Given this list of marker genes ATXN1 (ataxin 1), ADAM28, M6PR, FAM234B, ZDHHC23, SLC25A35, SSTR3, FOXD2, ACHE, ADPRHL1, C19orf38, DLD, WARS1, CACNA1B, NHERF4, SCN4A, ABHD3, ZSWIM5, HCN3, MORC2, ANKRD42, MCTP2, ZSWIM6, SCARB1, NCAN, SUV39H1, LRRC8B, HOMEZ, MAN1B1, ARID3B, MAP3K10, TYSND1, CEP85, MAP6, TDG, RMND5A, IL6R, PRRC1, C1orf210, IER2, PLXNA1, PCTP, ATXN3, INTS7, TRIM71, GALNT14, RBM20, MRPL30, SPATA31D4, DHX33, NDUFA2, ANKRD50, MAP3K13, SCUBE3, PI4K2B, RASSF3, ITGA8, SLC6A17, MAPK12, NEU1, KIF24, MYT1, ABCC5, ZNF543, KLC2, KCTD21, SLC16A6, NR6A1, SLC37A2, RFXANK, GARIN2 (golgi associated RAB2 interactor family member 2), ASIC1, DPP9, CARS2, SCRT2, DNAJB5, MYO18A, ZNF80, EIF2B5, SPEG, AMIGO2, FBXO42, TRIL, BAG4, WDR5, ORC2, MRAP, SAMD10, BCL2L14, CBX7, MTF1, SRF, AKT1S1, DUS1L, NIN, NT5DC1, RABEP2, FUT4, DAAM1, SYVN1, BTG2, IL16, GRB10, SH3TC2, SEMA4B, ASB13, RETREG2, MEMO1, UBE2G1, SEMA4D, LBH, TMEM135, SEC14L2, PSAPL1, TMEM132E (NCBI Gene Id 124842), CCR5, DRAM2, SCLY, KDM4C, ZSWIM4, CYP24A1, BLZF1, RAPGEF5, EIF1AD, ZKSCAN5, MSI1, SYDE2, MAP3K9, TBX4, ACTMAP (NCBI Gene Id 284325), GGA2, ZC3H7B, SEL1L, EBF4, ZFYVE1, LRP4, LRRC10B, EDN1, TBC1D1, UBR7 (NCBI Gene Id 55148), TNFSF4, RUFY3, NCKAP5L, TMTC2, DIRAS1, GANC, KCNH7, ITCH, MSRB3, RASGRF1, LACTB, DIP2A, ARMC7, KLF13, SULT4A1, MTFP1, OSBPL9, E2F3, SCN2B, ATXN7, VPS36, PCLO, TTPA, RNF168, PLEKHM3, KCNS3 (NCBI Gene Id 3790), SS18, MCL1, TNFAIP3, CRB2, PADI2, FBXO45, MAP2K7, ELOVL6, RAB3D, CDS2, NIPA1, TENT5A, SERTAD3, CRIPT, RASGEF1A, DIS3L2, LFNG, TRIAP1, ZFP62, HIF1AN (NCBI Gene Id 84175), TMEM63A, ANKRD33B, CDC37L1, FREM1, VTCN1, SCARB2, INTS15, PRTG, STARD13, EIF4EBP1, PHF20, LIN28A, KIAA0319L, SGPL1 (sphingosine-1-phosphate lyase 1), PPP2R5C, TRAF6, AGXT2, NCOR2, INO80D, RPS6KA1, ZNRF3, GJC1, GEMIN2, RASGRF2, ZNF691, DYNLT3 (NCBI Gene Id 6990), TSNARE1, RORA, ENPP1, CCNJ, SANBR, TMEM161B, BMF, TET2, NKAPD1, USP2, SNX18, NIPAL4, PPP4R3A, PPIL2, RAB6B, SPTB, UBE2R2, TOMM40, TAF9B, SAMD14, OLFML2A, SEC61A2, VDR, MFSD13A, CDC42BPG, AIFM1, CBFB, PHKA1, MBOAT2, MFSD9, SLC25A15, ZBTB7A, PRKAA2, ENTPD4, ESRRA, DICER1, SZRD1, SEMA4C, UBR2, PCGF6, HAPLN1, PCDH15, CHTF8, PDE7A, GPR107, SUN1, PLEKHA8, ST6GALNAC5, TRIM9, ATP10D, BORCS6, RABL6, C6orf47, JADE2, SMURF1, PODXL, FIBP, SOD2, SLC39A9, KCNK10, MAP3K11, HIC2, QSOX2, VPS37B, FMNL3, CLN6, PMM2, ZNF704, NUP210, IST1, USP38, FRMD5, TTC7A, ARHGEF39, FNDC3B, BAP1, ACER2, RAP1A, RFX5, E2F2, UBN1, NHSL3, REST, CNTNAP1, MMP11, CBLL1, ENPEP, LYZL6, SLC4A4, PHACTR3, ZNF385A, ZBTB37, RPL28, ZSCAN29, IRF4, HTR6, RBAK, PRDM1, DENND6A, TBC1D16 (NCBI Gene Id 54493), NBEAL2, SPSB4, RHOQ, ABHD6 (abhydrolase domain containing 6, acylglycerol lipase), NECAB3, TMEM120B, ARRB1, OAZ2, FLVCR2, FAM78A, DDX54, CACNB3, MKNK2, UCK2, BRWD1, LGI2, MFSD14B, CGN, C10orf105, VPS4B, LIPA, SOX11, ZBTB34, C1orf74, ALPK3, BAK1, CDK19, SLITRK6, PAFAH1B1, CDR2L, ZNF827, SPATA31D3, KCTD15, GOLGA5, TLE3, ZNF652, ENKUR, VCPIP1, PPAT, PPP1R37, TMEM168, P2RY2, CDH5, GCNT1, IL31, TOR2A, ABTB1, GTF3C3, DUSP6, BNIP2, XKRX, KCNA1, CPSF6, PKP4, ULK3, LCLAT1, GPATCH8, TRMT5, KHNYN (KH and NYN domain containing, NCBI Gene Id 23351), MAPRE2, TMPRSS13, CDC42SE1, TAFAZZIN, LIN28B, RBM7, DTX4, CCR2, CD5L, SLC35A4, ANAPC16, CSRNP1, SLC26A6, PCDH7, STX18, RYBP, DRP2 (dystrophin related protein 2), NPL, RREB1, MFHAS1, EPO, SEMA4F, PPME1, FBXW4, SLC38A9, MTMR3, KMT5C, SBNO1, FAM118A, FBXW8, SAXO1, IER3IP1, ESYT1, FAM169BP, SLC46A3, DOCK3, RFX3, SH3BP5L, EVA1A, KLHL6, HADHB, TSEN54, PRSS35, POFUT2, FGFR2, ETS1, BCAN, PDK3 (pyruvate dehydrogenase kinase 3, NCBI Gene Id 5165), KPNA6, FMO2, RETREG3, MXD4, MAMDC2, LPAR4, SARM1, SLC7A1, KCNIP3, NRXN1, PLCH2, IGSF11, HINFP, ISCU, ABCC4, DPH2, CYTH2, NAIF1, here is a description of the gene set: Genes predicted to be targets of miRBase v22 microRNA hsa-miR-4319 in miRDB v6.0 with MirTarget v4 prediction scores > 80 (high confidence targets). studied in species Homo sapiens Human Gene Set: MIR4319 from publication Chen Y, Wang X (PMID 31504780)